Given this list of marker genes STAR, POR, IFNG, ABCG4, SCAP, CYP7A1, FGF1, PRKAA1, CGA, MIR182, KPNB1, GNAI1, PAQR3, ADM, WNT4, NR5A2, SREBF1, MAPK1, MBTPS2, STARD4, ABCG1, BMP6, TNF, QKI, PRKACA (NCBI Gene Id 5566), NR1D1, FSHB, MIR96, SREBF2, DAB2, here is a description of the gene set: Any process that increases the frequency, rate or extent of the chemical reactions and pathways resulting in the formation of steroids, compounds with a 1,2,cyclopentanoperhydrophenanthrene nucleus. species: Homo sapiens Human Gene Set: GOBP_POSITIVE_REGULATION_OF_STEROID_BIOSYNTHETIC_PROCESS